Given this list of marker genes Praf2, Prmt8, Appl2, Mgll, Pdzph1, Tnrc18, Zfp7, Primpol, Slc4a4, Kctd10, Pde1a, Cand1, Sertad2, Pml, Cdk19, Csgalnact2, Rnf20, Slc26a5 (solute carrier family 26, member 5), Trps1, Lrtm2, Vstm5, Poc5, Spin1, Pde3a, Kansl1l, Tgfb2, Klhl23, Prkab1, Dync1i1, Smim14, Prss53, Fam124b, Crabp2, Nr4a3, Lifr, Lgals1, Tnrc6b, Sft2d3, Carmil1, Uvssa, Pgf, Cxcl12, Steep1, Hmox2, Hapstr1, Smim15, Cacng6, Zfp772, Rab1a, Mia3, Cnih4, Mtfr1, Shb, Aff1, Fbrs, Trabd2b, Cdkl4, Tcerg1, Ccdc97, Adamts3, Ptafr, Pea15a, Amotl2, Kcnb1, Ccr4, Gask1a, Tmbim1, Zfp428, Lims1, Reps2, Aak1, Zfp12, Fam210b, Lrrc32, Mdm2, Kank2, Mmaa, B4galnt2, Hcar2, Btbd3, Slc16a10, Fam136a, Kazn, Kcnab1, Ipo8, Syt7, Derl2, Zim1, Abce1, Suclg2, Vash1, Pten, Rcan2, Casr, Niban1, Adcy1, Nrp2, Pmm2, Sfmbt2, Kbtbd4, Kctd17, Tia1, Mpig6b, Entpd7, Atrn, Atp2a3, Atg16l2, Zfp329, Tmc3, Plag1, Patz1, Ints3, Csf2ra, Stc1, Aff3, Wwtr1, Slc7a2, Tln2, Arhgap21, Cacna1s (calcium channel, voltage-dependent, L type, alpha 1S subunit), Eif4b, Zbed3, Fmn2, Fkbp1b, Ska1, Kcnn3, Fahd1, here is a description of the gene set: Genes predicted to be targets of miRBase v22 microRNA mmu_miR_7688_3p in miRDB v6.0 with MirTarget v4 prediction scores > 80 (high confidence targets). species: Mus musculus Mouse Gene Set: MIR_7688_3P from publication Chen Y, Wang X (PMID 31504780)